Given this list of marker genes THG1L, TYW5, ADAT3, CTU1 (cytosolic thiouridylase subunit 1), CTU2, TRMT61A, TRDMT1, QTRT1, EPRS1, TPRKB, WDR4, PUS7, FTSJ1, TRMT13, ADAT1, DUS2, QTRT2, METTL1, OSGEP, TP53RK, PUS1, TRMT6, ADAT2, TRMT10A, TRMT44, URM1, NSUN6, LCMT2, TRMT9B, CDKAL1, TRMT11, LAGE3, TRIT1, THADA, ALKBH8, TYW1, GON7, TYW3, NSUN2, TRMT12, TRMT1, TRMT5, PUS3, TRMT112, here is a description of the gene set: species: Homo sapiens Human Gene Set: REACTOME_TRNA_MODIFICATION_IN_THE_NUCLEUS_AND_CYTOSOL tRNA modification in the nucleus and cytosol